Given this list of marker genes ABHD1, CEL, SIAE, ABHD3, ABHD2, here is a description of the gene set: species: Homo sapiens Catalysis of the reaction: an acetic ester + H2O = an alcohol + acetate. Human Gene Set: GOMF_ACETYLESTERASE_ACTIVITY